Given this list of marker genes Hpn, Ovol2, Mad2l2, Tgfb2, Nkx2-1, Spsb3, Dab2ip, Usf3, Gata3, Pten, Vasn, Nog, Fbxo11, Efna1, Spry2, Trim62, Adipor1, Tgfbr3, Mark1, Ldlrad4, Pawr, Tsc2, Sdhaf2, Gsk3b, Ppp2ca, Spred3, Fuz, Vegfa, Kat8, Spred1, Foxa1, Dact3, Sfrp2, Foxa2, Spry1, Epha4, Il17rd, Dsg2, Sfrp1, Spred2, Zfp750, here is a description of the gene set: Mouse Gene Set: GOBP_NEGATIVE_REGULATION_OF_EPITHELIAL_TO_MESENCHYMAL_TRANSITION Any process that decreases the rate, frequency, or extent of epithelial to mesenchymal transition. Epithelial to mesenchymal transition where an epithelial cell loses apical/basolateral polarity, severs intercellular adhesive junctions, degrades basement membrane components and becomes a migratory mesenchymal cell. species: Mus musculus